The following is a description of a gene set: studied in species Mus musculus The activity of binding to and activating specific cell surface receptors, thereby inducing behavioral, developmental, or physiological response(s) from a responding organism or cell. The substance may be released or retained on the cell surface. Pheromones may serve as a specific attractant, social communicator, or sexual stimulant. Mouse Gene Set: GOMF_PHEROMONE_ACTIVITY, and this is the list of marker genes: Esp18, Mup20, Esp15, Esp38, Esp4, Esp6, Mup1, Esp23, Esp22, Esp34, Esp3, Esp8, Esp1, Esp16, Esp36, Gm44501, Esp24 (NCBI Gene Id 100126776), Esp31